The following is a description of a gene set: Human Gene Set: GOBP_PROTOPORPHYRINOGEN_IX_BIOSYNTHETIC_PROCESS species: Homo sapiens The chemical reactions and pathways resulting in the formation of protoporphyrinogen IX., and this is the list of marker genes: ALAS2 (5'-aminolevulinate synthase 2), HMBS, CPOX, ALAD, IREB2, UROD, ALAS1, UROS, PPOX